Given this list of marker genes ITGAL, MBNL1, STK10, ARHGEF3, GIMAP6, RIPOR2, BIN2 (bridging integrator 2), LCP2, PTPRC, SNRK, CYTH1, BTN3A2, STK38, HECA, RASGRP1, CLEC2B, KLRB1, SYNRG, CASP8, GPR65, CYTIP, MSL1, PARP8, JAK1, CCL5, BTN3A1, BTN3A3, SEMA4D, here is a description of the gene set: Neighborhood of SNRK SNF related kinase in the GNF2 expression compendium Human Gene Set: GNF2_SNRK Neighborhood of SNRK species: Homo sapiens